The following is a description of a gene set: The progression of the olfactory lobe over time from its initial formation until its mature state. The olfactory lobe is the area of the brain that process the neural inputs for the sense of smell. Human Gene Set: GOBP_OLFACTORY_LOBE_DEVELOPMENT species: Homo sapiens, and this is the list of marker genes: DLX2, ROBO1, SKI, ERBB4, CRTAC1, ROBO2, ATP1A2, FUT1, SALL1, UNCX, SEMA7A, FEZF1, LRRK2, OGDH, CSF1R, AGTPBP1, SRF, ATF5, ZIC3, NR2E1, SLIT3, ID2, CHD7, EFNA2, WNT5A, EOMES, RAC1, SLIT1, ZIC1, TTC8, SLIT2, RPGRIP1L, EXT1, GSX2, KIF14, DLX5, SEMA3A, ARX, LHX2